The following is a description of a gene set: from publication Chen Y, Wang X (PMID 31504780) Genes predicted to be targets of miRBase v22 microRNA hsa-miR-1199-5p in miRDB v6.0 with MirTarget v4 prediction scores > 80 (high confidence targets). Human Gene Set: MIR1199_5P studied in species Homo sapiens, and this is the list of marker genes: B3GALT5, PITPNM3, CD22, MTF1, HID1, AOPEP, SLC7A6, APOL6, TP63, FBRS, SOX5, RPS6KL1, TREML2, SLC25A42, ZNF512B, NLRP2B, GCSAM, HTR1A, SNX22, PAX7, ANKRD13B, FAM98A, FMNL2, TANC2, TMED7, CARNMT1, MTMR4, NAV1, NAA60, PKNOX1, NFATC3, ERCC4, ELK4 (NCBI Gene Id 2005), STX6, HIC2, BTBD7 (NCBI Gene Id 55727), TP53INP2 (tumor protein p53 inducible nuclear protein 2), GNAT1, KANK4, KRBA1, MAPK1, VKORC1, LRRC17, CHD3, PPARGC1B, GAPT, SYNC, EIF3C, MPIG6B, CEMIP, GLO1, DYNAP, DAGLA (diacylglycerol lipase alpha), OLA1, SET, PIP5K1C, CCL22, FYB2, WDR6, GLRX, MBD6, PTBP2, N4BP3, ZNF395, ARMH3, ISG20L2, USP46 (NCBI Gene Id 64854), ST6GALNAC1, ATF3, CPN2, NKIRAS2, FNIP1, RAB6B, MARK2, SH2D2A, RRP8, EIF3CL, PPIA, GNAO1, NAP1L5